Given this list of marker genes Smap2, Sox4, Jarid2, Atp5mg, Ckap4, Dhrs3, Idh3g, Cnbp, Tnip1, Mga, Tmem176b, Prdx6, Sult1a1, Mrpl43, Clec4b1, Ier2, Zeb2, Alox5ap, Smc6, Zfp36l2, Polr2e, Adgre1, Ccdc88a, Dctpp1, Naca, Bin1 (NCBI Gene Id 30948), Ddhd2, Cep250, Mrps16, Rgs18, Nap1l1, Ncaph2, Gpx4, Susd3, Ahr, Gpi1, Use1, L3mbtl3, Ptp4a3, Sft2d2, Dock10, Fcho2, Slc38a1, Raph1, Eif3h, Ppfia4, Ctdsp2, Cdc37l1, Kctd12, Tmem123, Epb41l4aos, Mapk14, Atp5pd, Fto, Csad, Supt16, Map4k1, Xist, R3hdm4, Cd37, Prkcb, Hes6, Otulinl, Bmyc, Cd244a, Brd1, Mdp1, Trf, Spn, Scp2, Apbb1ip, Akr7a5, Cebpg, Ssbp4, Ramp1, Snhg12, Pten, Tmem109, Akap13, Mrpl12, Evi5, Rnf130, Pgls, Ube3a, Smarcc2, Atrx, H2-Ab1 (histocompatibility 2, class II antigen A, beta 1), Top2b, Fubp1, Fau, Itpripl1, Septin3, Trps1, Coro1a, Cx3cr1, Hook3, Uggt1, Klf4, Dab2, Aplp2, Tle5, Arhgap9, Zfp36l1, Hpgd, Bcap29, Washc2, Exosc5, Ncoa3, Cd200r1, Mark3, Ccpg1, Tm9sf3, Supt20, Bnip3l, Adam23, Atp5mc2, Tmem156, Il13ra1, Fcor (NCBI Gene Id 68234), Pot1b, Eif4ebp1, L1cam, Hmgn1, Atp13a3, Ypel3, Pqbp1, Dhrs7, Zzz3, Foxp1, Golga4, Stk17b, Cdc40, Marveld1, Fcgrt, Paip2, Gabarapl1, Creg1 (NCBI Gene Id 433375), Glrx5, Syngr2, Arglu1, H2-Ob, Rfx7, Nedd4, Add3, Stard9, H2-DMa, Clec4a2, Pnisr, Nop10, Ikbkb, Eif2a, Etfb, Phactr2, Lrrk2, Elovl5, Macf1, Dpm3, Tsc22d3, Arl11, Mapre2, Man1a, Eif3e, Cdk2ap2, Cebpz, Ttc3, Ncor1, Emc6, Shtn1, Fam107b (family with sequence similarity 107, member B), Ttc14, Eef1b2, Smarca2, Slc39a10, Crybg3, Sfxn3, Man2b1 (mannosidase 2, alpha B1), Clk1, Ppp1r14b, Ank, Brd3, Dock5, Abce1, Arl4c, Rabl6, Fth1, Zmynd11, Stap1, Dnajc1, Glo1, Guk1, Fam234b, Fuca1, Fam168a, Mbtps1, Ints6l, Ankrd44 (NCBI Gene Id 545320), Sgms1, Il17ra, Pabpc1, Niban1, Ssbp3, Zmynd8, H2az1, Synrg, Fermt3, Tmed3, Eid1, Agpat4, Cd209d, Pold4, Ccdc47 (coiled-coil domain containing 47), Klhl24, Flt3, Sh2d1b1, Purb, H2aj, Ssh2, Arhgap18, Tnfaip8, Bcl11a, Eef1d, Gnpda1, Imp3, Abhd17a, Ccr2, Lifr, Csf1r, Bmp2k, Fh1, Cd209a, Tmem176a, Slc1a5 (NCBI Gene Id 269874), Eif3f, Rmnd5a, Tomm20, H2-DMb1, Hnrnpr, Fgd2, Slc43a2, Ivns1abp, Eef1g, Hdac5, Eif4ebp2, Tpm1, Mxd4, Plbd1, Lyst, Dna2, Zfand6, Cox7a2l, Fgfr1, Parp1, Fcgr2b, Cbl, Cd33, Camk1d, Emc10, Ccdc107, Mef2c, Gnai2, Pan3, Btg2, Slc48a1, Cnih1, Pik3cg, Hfe, Zfp398, Krtcap2, Pnkd, Slc25a5, Irf4, Smad7, Prkar2a, Rp2, H3f3a, Trappc5, Maf1, Ipo7, Dync1li2, Hmgb1, Chil5, Arhgdib, Tmem234, Prcp, St8sia4, Atg5, Trmt112, Tia1, Anp32b, Emb, Csnk1g3, Herc1, Zfp706, Timm13, Mri1, Crebrf, Ppm1m, Serbp1, Hlx, Supt4a (SPT4A, DSIF elongation factor subunit), Klrd1, Tmcc1, Reep5, Mrpl34 (NCBI Gene Id 94065), D8Ertd738e, Txnip, B4galt6, Txndc15, Abca9, Tacc1, Gltp, Bri3bp (NCBI Gene Id 76809), Slc66a2, Eef1a1, Eif4b, H2-Aa, Eef2, Tnfrsf13b, Cd209e, H1f2, Kmt2e, Sf3b2, Arhgef6, Aph1c, Egr2, Mtdh, Mia2, Ctnna1, Slc2a3, Sec11c, Inpp5d, Il6st, Pcbp2, Hnrnpa1, Npm1, Jmjd1c, Unc119, Map4k4, Snx27, B4galnt1, Eif3k, Zdhhc20, Tsc22d1 (NCBI Gene Id 21807), Pmaip1, Mink1, Il6ra, Smc3, Ifngr1, Sirpa, Gsr, Wdfy2, Git2, Nsa2, Rxra, C1qbp, Clns1a, Ucp2 (uncoupling protein 2 (mitochondrial, proton carrier)), Slc25a36, Asap1, Celf4, Pid1, Atraid, Egln1, Cyp4f16, Casp6, H2-Eb1, Gfra2, Pfdn5, Gdi2, Pdcd4, Cdyl, Ctsh, Specc1, Slc12a6, Cnn2, Ppp1r21, Sptssa, Cd48, Rnf150, Mcemp1, Sulf2, Ptgs2, Gpr68, Ssr4, Scd2, Znrf2, Nhp2, Kcnq1ot1, Alcam (activated leukocyte cell adhesion molecule), Mrpl52, Cdkn1b, Fbl (fibrillarin), Dhx40, Zfp787, Rasgrp2, Gar1, Jun, Lrwd1, Tmem64, Phf14, Rack1, Ap1s2, Pi16, Pbxip1, Rp9, Sgpp1, Rnd3, Spr, Ogt, Nucks1, Cox6b2, Qdpr, Ccdc88c, Pygo2, Emsy, Eif4a2, Fosb, Gpx1, Atp5f1a, Ppp2r5c, Septin9, Tbc1d9, Hcfc1, Fos, Cnpy2, Tubb5, Cd79b, Zfp871, Ndufa6, Cers5, Dusp1 (dual specificity phosphatase 1), here is a description of the gene set: Mouse Gene Set: CUI_CDC2_IFNA1_RESPONSE_DN Genes negatively differentially expressed in cell type: cDC2 (conventional dendritic cell type 2) upon treatment with cytokine: IFN-α1 in mouse lymph nodes in vivo. studied in species Mus musculus from publication Cui A, Huang T, Li S, Ma A, Pérez JL, Sander C, Keskin DB, Wu CJ, Fraenkel E, Hacohen N (PMID 38057668) Cytokines mediate cell-cell communication in the immune system and represent important therapeutic targets. A myriad of studies have highlighted their central role in immune function, yet we lack a global view of the cellular responses of each immune cell type to each cytokine. To address this gap, the authors created the Immune Dictionary, a compendium of single-cell transcriptomic profiles of more than 17 immune cell types in response to each of 86 cytokines (>1,400 cytokine-cell type combinations) in mouse lymph nodes in vivo. A cytokine-centric view of the dictionary revealed that most cytokines induce highly cell-type-specific responses. For example, the inflammatory cytokine interleukin-1β induces distinct gene programmes in almost every cell type. A cell-type-centric view of the dictionary identified more than 66 cytokine-driven cellular polarization states across immune cell types, including previously uncharacterized states such as an interleukin-18-induced polyfunctional natural killer cell state.